The following is a description of a gene set: Th1 and Th2 cells arise from a common precursor cell in response to triggering through the TCR and cytokine receptors for IL-12 or IL-4. This leads to activation of complex signaling pathways, which are not known in detail. Disturbances in the balance between type 1 and type 2 responses can lead to certain immune-mediated diseases. Thus, it is important to understand how Th1 and Th2 cells are generated. To clarify the mechanisms as to how IL-12 and IL-4 induce Th1 and Th2 differentiation and how TGF-beta can inhibit this process, we have used oligonucleotide arrays to examine the early polarization of Th1 and Th2 cells in the presence and absence of TGF-beta after 0, 2, 6 and 48 hours of polarization. Genes up-regulated in CD4 T cells: untreated (0h) versus activated by anti-CD3 and anti-CD28 (2h). from publication Lund R, Aittokallio T, Nevalainen O, Lahesmaa R (PMID 14607935) studied in species Homo sapiens Human Gene Set: GSE2770_UNTREATED_VS_ACT_CD4_TCELL_2H_UP, and this is the list of marker genes: ZFP36L1, DGLUCY, DBP, PPM1L, ARMC3, CD40, PLBD1, PEX11G, AKNA, TRIM7, CRTC1, PTPN14, RELCH, KCTD6, ABCB1, ITPR2, FBXW10, CYTH4, ZSCAN26, IQSEC1, CHDH, CD22, PARM1, CD79A, NAMPT, P2RX4, CCL22, DNAJB2, LDB1, ZBTB11, TGFBR2, ABHD6, ADORA1, SOCS3, GNL2, LRRC8C, AHDC1, S1PR1, HSPA5, RAP1B, PCP4, MACIR, TMEM204, DNAJA4, PLEC (NCBI Gene Id 5339), LGALS3BP (NCBI Gene Id 3959), TCF12 (NCBI Gene Id 6938), AKAP7, CYRIA (NCBI Gene Id 81553), APPL2, USE1, FILIP1L, CYP4F3, SLC3A2, EEIG1, RARG, STAT1, EPCAM, KLF4, CARNS1, TK2, ADCK1, FAAH, TTC38, CYB561A3, GPR132, STARD10, FBXL12, PBXIP1, BTLA, GPATCH2, COMMD3, DTX4, SH2D2A, BBS2, BST2 (NCBI Gene Id 684), ABCA1, TRAF3, MICU3, RABAC1, TRIP11, POU2F2, C21orf91, MYCBP2, TBC1D10C, SGSM2, PIEZO1, SRGAP3, NLRC5, AFF3, CDK16, LY6E, ORAI1, CHIC1, FOSL2, TNKS1BP1, TM7SF3, ZFP14, LFNG, CD72, SPAG9, CTPS2, MAN1A1, TMEM230, GRAP2 (GRB2 related adaptor protein 2), AGRN, DDX60, HLA-DOA, KLF2, TRIM26, SAMD9L, CHD2, LGALS4, GCA, TNFRSF18, MX2, SRMS, BCKDHB, LAMB3, ARHGAP5, FAM120B, INTS4, EZH1, GSAP, IL2RB, ETV3, MLLT3, DHRS7, SERPINB1, FNDC10, NFKBIE, KCTD14, HHEX (NCBI Gene Id 5556), ICE1, KCTD12, DNAAF9, CTSH, METAP1D, TUBA4A, GGPS1, TATDN3, GPR137B, ENO3 (NCBI Gene Id 2027), LRRC8A, AMZ1, MARCKS, CEBPB, ANKRD44, TMEM176B, CERS4, CAPN2, ABCA2, KHK, CCSER2, IRS2 (NCBI Gene Id 90066), LANCL1, SLC39A4, SPART (spartin), NCF1, B4GALT5, MARF1, TMCC3, SIDT1, CACNA1D, MCOLN3, B4GALNT1, PLAU, DDRGK1, TAFAZZIN, IDS, CCNT2, IL10RB, MGA, ACP6, HSD17B8, SLC50A1, SP4, SCAMP3, DOP1B (NCBI Gene Id 9980), PLD2, AHI1, TSPAN32, UBXN6, NAT9, STX17, ANXA6, JUNB, PPCDC, S100A11, SNAP47, ELL, BBS9, TOM1L2, ATXN1, CFAP96, KLHL18, PDLIM1, EDEM2